Given this list of marker genes EXOSC6, EXOSC8, MAPKAPK2, EXOSC3 (NCBI Gene Id 51010), DCP1A, XRN1, EXOSC7, EXOSC1, YWHAB, DCP2, EXOSC2, DIS3 (DIS3 homolog, exosome endoribonuclease and 3'-5' exoribonuclease), AKT1, EXOSC9 (exosome component 9), ZFP36L1, EXOSC4, EXOSC5 (NCBI Gene Id 56915), here is a description of the gene set: Butyrate Response Factor 1 (BRF1, ZFP36L1, not to be confused with transcription factor IIIB) binds AU-rich elements in the 3' region of mRNAs. After binding, BRF1 recruits exonucleases (XRN1 and the exosome) and decapping enzymes (DCP1a and DCP2) to hydrolyze the RNA. The ability of BRF1 to direct RNA degradation is controlled by phosphorylation of BRF1. Protein kinase B/AKT1 phosphorylates BRF1 at serines 92 and 203. Phosphorylated BRF1 can still bind RNA but is sequestered by binding 14-3-3 protein, preventing BRF1 from destabilizing RNA. BRF1 is also phosphorylated by MK2 at serines 54, 92, 203, and at an unknown site in the C-terminus. It is unknown if this particular phosphorylated form of BRF1 binds 14-3-3. Reactome Pathway: Butyrate Response Factor 1 (BRF1) binds and destabilizes mRNA studied in species Homo sapiens part of: Regulation of mRNA stability by proteins that bind AU-rich elements